The following is a description of a gene set: Genes positively differentially expressed in cell type: cDC2 (conventional dendritic cell type 2) upon treatment with cytokine: TNF-α in mouse lymph nodes in vivo. from publication Cui A, Huang T, Li S, Ma A, Pérez JL, Sander C, Keskin DB, Wu CJ, Fraenkel E, Hacohen N (PMID 38057668) Mouse Gene Set: CUI_CDC2_TNFA_RESPONSE_UP studied in species Mus musculus Cytokines mediate cell-cell communication in the immune system and represent important therapeutic targets. A myriad of studies have highlighted their central role in immune function, yet we lack a global view of the cellular responses of each immune cell type to each cytokine. To address this gap, the authors created the Immune Dictionary, a compendium of single-cell transcriptomic profiles of more than 17 immune cell types in response to each of 86 cytokines (>1,400 cytokine-cell type combinations) in mouse lymph nodes in vivo. A cytokine-centric view of the dictionary revealed that most cytokines induce highly cell-type-specific responses. For example, the inflammatory cytokine interleukin-1β induces distinct gene programmes in almost every cell type. A cell-type-centric view of the dictionary identified more than 66 cytokine-driven cellular polarization states across immune cell types, including previously uncharacterized states such as an interleukin-18-induced polyfunctional natural killer cell state., and this is the list of marker genes: Klhdc4, Cxcl9, Kcnk6, Ccdc88a, Tnfaip3, Etf1, Edem1, Psma6, Mapkapk2, Cdkn1a, Bax, Mrpl14, Jak2, Hif1a, Ptger4, Rtn1, H2-Q6, Bzw1, Selenos (NCBI Gene Id 97368), Marcks, Lcp1, Gosr2, Psmb7, Ppp4r2, Aamp, Tma7 (translational machinery associated 7), Clec4n, S100a4, Taf10, Manf, Gpr132, Klhl9, Cst7, Thap2, Dnajc3, Sin3b, Wdr1, Ube2n, Runx3, Itgb1 (NCBI Gene Id 70812), Atp2a2, Cct8, Atp5f1b, Lilrb4b, Supt6, Fscn1, Socs2, Filip1l, Cd83, Tmem167, Efhd2, Cacnb3, Gpr84, Slc35b1, Myo10, Ubxn2a, Cish, Tmed10, Gpr183, Ikzf1, Eif4a1, Hnrnpa3, Lmnb1, Serpinb1a, Rgs1 (regulator of G-protein signaling 1), Serpinb9, Cd53, Arl1, Snx1, Emd, Jpt2, Sav1, Clptm1, Atp6ap2, Ccl17, Slc2a1, Nfkb2, Slc7a11, Ankrd33b, Il7r (NCBI Gene Id 223338), Id2, Tle3, Zwint, Lsm4, Ifitm2, Mtmr4, St3gal1, Gpr137b, N4bp1, Ap2m1, Slc39a1, H2-Eb2 (NCBI Gene Id 631971), Fabp5, Hvcn1, Timd4, Tuba1c, Pfn1, Rab8b, Zfp36l1, Sting1 (stimulator of interferon response cGAMP interactor 1), Ass1, Dusp2, Snap23, Gpbp1, Alyref, Mllt6, Fnbp1l, Gca, Map3k14, Dhx9, Msr1, Aebp2, Samsn1 (NCBI Gene Id 67742), Mapre1, Rap2a, Psme2, Kdm5c, Pik3r5, Syk, Tcp1, Mreg, Crybg1, Kdm6b, Lsp1, Csrnp1, Larp1, Zdhhc3, Peli1, H2-Q7, Nr4a3 (NCBI Gene Id 18124), Csrp1, Eif3c, Myl6, Dusp5, Arpc5, Crtc2, Hnrnpk, Zfc3h1, Sh3pxd2b, Dok2, Dnajb11, Plxna1, Myo1e, Flna, Etv3, Acp2, Ptpn1, Bcl3, Ywhaq, Stat5a, Dok1, Iscu, Parl, Ccdc71l (NCBI Gene Id 72123), Actr3, Tarm1, Tmem131l, Htr7 (5-hydroxytryptamine (serotonin) receptor 7), Pgap2, Rbm25, Srsf2 (serine and arginine-rich splicing factor 2), Eif3a, Pmvk, Pafah1b1, Mrpl38, Cnn2, Psmd4, Arl8b, Ppa1, Cd200, Gfra2, Traf6, Capzb (NCBI Gene Id 80668, capping actin protein of muscle Z-line subunit beta), Plpbp, Rbm8a, Vcp, Prnp, Sbno2, Rnf19b, Rbm3, Fhod1, Ssr2, Cers6, Ly75 (lymphocyte antigen 75), Socs3, Sult1a1, Anxa2, Psmd1, Tmed5 (NCBI Gene Id 74336), Tmem106a, Selenok, Csf2rb, Nras, Erh, Cyb5b, Psmd7, Mkrn1, Tpm4, Canx, Elp5, Slc39a14, Adpgk, Btg1, Fas, Psmd10, Nck2, Tm9sf2, Tmem168, Cd8a, Sfpq, Arf4, Atp2b4, Nfya, Castor2, Idi1 (NCBI Gene Id 319554), Map4k4, Clic4, Tspan3, Eif1ax, Casp6, Sar1a, Birc2, Pfkp, Rab18, Slc30a4, Atxn7l1, Car2, Tbcb, Cytip, Lpl, Cyria, Rab21, Cd274, Ostc, Dr1, Kif1a (NCBI Gene Id 403189), Adam9 (ADAM metallopeptidase domain 9), Pirb, Cpeb4, Mif4gd, Mthfs, Cdk2ap2, Ubxn4, Nfat5, Nectin2, Nlrc5, Srsf7, Timp1, Tbc1d4, Morf4l2, Serpina3g, Fkbp5, Atp6v0b, Prdm1, Jtb, Cstb, Mrpl17, Malt1, Psenen, Slc3a2, Psme3, Adam8, Dnajb6, Sumo2, Ehbp1l1, Pdgfb, Zmynd8, Spred1, Eif4g1, Oat, Necap2, Ube2g2, Lrrc59, Pdlim4, Tagln2, Ddt, Tank, Rhbdf2, Gadd45b, P2ry10, Ctsz, Zfp593, Sdhaf1, Lcp2, Ube2f, Basp1, Tmem176a, Nipal1, Cd38, Ctdnep1, Bcl2a1b, Entr1, Psmd11, Cd86, Spint2 (NCBI Gene Id 97345), Foxp4, Uap1, Mmp14 (NCBI Gene Id 17387), Nrp2, Poglut1, Vcam1, Ost4, Bcl2a1d, Hspa9, Pdcd1lg2, Bola3, Arap2, Sod2, Fchsd2, Clec4d, Traf1, Ahcyl2, Gpr55, Hdlbp, Fyn, Gsr, Slamf9, Sdf4, Stat3, Clec5a, Bcl2l14, Sdc4, Plscr1, Eif5a, Pdia6, AA467197 (expressed sequence AA467197), Igsf9, Klf7, Hbegf, Ptafr, Appl1, Anapc15, Hspa5, Cd63 (NCBI Gene Id 98116), Gnai3 (NCBI Gene Id 99910), Tnip2, Mgat2, Rap2b, Apobec3, Apol7c, Slc38a2, Zfand3, Slc15a3, Arhgdia, Gtf2a1, Mob3c, Tmem176b, Cflar, Pnpla8, Rftn1, Mapk1ip1l, Anxa3, Plekha1, Lrrk1, Tnip1, Yrdc, Dynlrb1, Nectin1, Glipr2, Vmp1, Srpra, Dhx15, Grb2, Atp5mc1, Rtn4, Adora2a, Swap70, Gda, Mrps28, Btla, Foxn3, Ccr7, Etv6, Mt1, Fubp1, Pfkfb3, Rspry1, Actg1, Cd24a, Relb, Nfkbie, Znrf1, Flnb, Clec4e, Edf1, Hip1, Tmcc3, Il4i1, Apod, Atp11a, Cox17, Txnrd1, Nudt17, Nus1, Csf2rb2, Litaf, Ppp3r1, Rras2, Pdia4, Gnb1, Nfkb1, Ube2z, Cfp, Chst7, Gadd45g, Ak2, Atxn2l, Rcl1, Ifitm1, Acvr2a, Cyth1, Ccser2, Ccl22, Pdia3, Cd82, Pogk, Cd44, Mt2, Irf5, Prelid3b, Sub1, Creld2, Sec22b, M6pr, Bhlhe40, Grk3, Rbx1, Ccnd2, Timm17a, Snx11, Nfe2l1, Rassf2, Rab14, Eif4g2, Tbc1d1, Cxcl16, Dnajc2, Pacsin2, Sema6d, Gramd4, Ywhab, Maff, Dram1, Bud31, Zfp516, Ppp2r1a, Ms4a6d, Arl5a, Foxn2, Srgn, Ube2i, Nr1h3, Tspan13, Tspo, Ergic1, Ldha, Spcs2, Sema4a, Hnrnpc, Mob3a, Cpne2, Kdr, Abracl, Dapk3, Nckap1l, Psmb6, Ybx1, Tnfrsf18, Anxa7, Herpud1, Tmem39a, Tspan33, Col27a1, Mrpl52, Ehd1, Myo1g, Pcgf5, Eif6, Hnrnpf, Tap2, Stx11, Cd40, Ciao2a, Tnfaip2, Mfhas1, Icam1, Tmem123, Gucd1, Nup88, F11r, Map4k1, Sema7a, Adam19, Slc26a2, Mvp, Fpr2, Xbp1, Rasgrp1, Sel1l, Avpi1, Adap1, Icosl, Tfec, Cfl1, Chchd4, Vasp, Calr, Nubp1, Eea1, Bcl2a1a, Myl12a, Birc3, Marcksl1, Rab20, Cyp7b1, Nsf, Snn, Dcun1d5, Nup62, Atf5, Myh9, Vamp8, Mat2a, Itm2c, Cfb, Plek, Nfkbia, Hsp90b1, Sarnp, Dnajb9 (DnaJ heat shock protein family (Hsp40) member B9), Cyrib, Ubl4a, Ell2, Eif1, Plekhb2, Bmp2k, Arhgap31, Stard7, Pdcl3, Syncrip, Hnrnpa2b1, Il1rn